Given this list of marker genes Kcnk6, Kcnk9, Kcnip2, Kcnk4, Kcnk13, Kcnd1, Kcnk3, Kcnk12, Kcnb1, Kcnd3, Kcna5, Kcnk2, Kcnk18, Kcnk10, Kcnd2, Kcnt1, Kcnk7, Kcnk5, Kcna3, Kcnq1, Kcnk16, Kcna2, Pkd2, Kcnt2, here is a description of the gene set: Mouse Gene Set: GOMF_OUTWARD_RECTIFIER_POTASSIUM_CHANNEL_ACTIVITY Enables the transmembrane transfer of a potassium ion by an outwardly-rectifying voltage-gated channel. An outwardly rectifying current-voltage relation is one where at any given driving force the outward flow of K+ ions exceeds the inward flow for the opposite driving force. species: Mus musculus